Given this list of marker genes Myh1, Ttn, Myh7, Myh11, Myh2, Myh6, here is a description of the gene set: A filament of myosin found in a muscle cell of any type. studied in species Mus musculus Mouse Gene Set: GOCC_MUSCLE_MYOSIN_COMPLEX